The following is a description of a gene set: Human Gene Set: GOMF_TELETHONIN_BINDING Binding to telethonin, a protein found in the Z disc of striated muscle and which is a substrate of the titin kinase. species: Homo sapiens, and this is the list of marker genes: CSRP3, MYOZ1, MYOZ3, KCNE1, MYOZ2, BMP10, TTN